The following is a description of a gene set: Pathway Definition from KEGG: FGF -> FGFR -> GRB2 -> SOS -> RAS -> RAF -> MEK -> ERK FGF-FGFR-RAS-ERK signaling pathway. Pathway ID: N00019. Pathway type: Reference. Pathway class: nt06261 Gastric cancer. species: Homo sapiens Human Gene Set: KEGG_MEDICUS_REFERENCE_FGF_FGFR_RAS_ERK_SIGNALING_PATHWAY, and this is the list of marker genes: KRAS, FGF19, FGF9, FGFR3, FGF3, ARAF, BRAF, FGF1, FGF10, FGF16, SOS2, FGF23, FGF22, FGF6 (fibroblast growth factor 6), FGF18, FGF20, RAF1, FGF17, MAPK3, GRB2, HRAS, FGF2, MAP2K1, FGFR1, FGF5, FGFR4, FGF7 (NCBI Gene Id 82955), FGF8, SOS1, NRAS, FGF21 (fibroblast growth factor 21), FGFR2, MAPK1, FGF4, MAP2K2